Given this list of marker genes Aurkb, Ppp2cb, Ska1, Ndel1, Ppp2r1a, Brk1, Dynll1, Diaph2, Rhod, Seh1l, Nckipsd, Mapre1, Pafah1b1, Cenpk, Clip1, Ndc80, Evl, Ywhae, Cenps, Incenp, Noxo1, Prkcz, Ppp2r5a (NCBI Gene Id 226849), Cenpq, Nox1, Diaph1 (diaphanous related formin 1), Sgo1, Kif18a, Kif2b, Dync1i1, Klc3, Tubb2b, Dync1li1, Nup85, Clasp2, Ctnnb1, Tuba3b, Fmnl3, Pik3c3, Myl6, Tubb2a (NCBI Gene Id 263448), Gopc, Dsn1 (NCBI Gene Id 99407), Cenpe, Fmnl1, Ahctf1, Ppp1r12b, Kif2a, Kif14, Kntc1 (kinetochore associated 1), Flna, Myh14, Rps27, Ncf2, Ercc6l, Pak2, Actb, Rcc2, Spc25, Kif2c, Cyfip1, Rac2, Cybb, Ptk2, Zw10, Myh9, Rhob, Ppp2r5d, Plk1, Nup107, Arpc1a, Pfn2, Rhoa, Daam1, Ar, Mad2l1, Nup133, Cenph, Cenpn, Nuf2, Abi1, Rhoc, Wasf2 (NCBI Gene Id 52063), Mis12, Fmnl2 (NCBI Gene Id 71409), Nckap1, Ywhag, Calm2, Nudc, Tubb1 (tubulin, beta 1 class VI), Dvl1, Ywhah, Myl12b, Ppp1cc, Cftr, Ywhaz, Ncf1, Wasf1, Ywhab (NCBI Gene Id 80438), Wasf3, Nf2, Noxa1, Dvl2, Ppp2r5b, Dlg4, S100a9, Nup37, Pkn2, Mapk1, Pin1, Tubb4b, Rps27rt (ribosomal protein S27, retrogene), Prkcb, Tuba8, Ppp1cb, Srgap2, Tubb3, Arpc4, Rangap1, Tuba1b, Nup43, Rhpn2, Lin7b, Myl9, Tuba3a, Clasp1, Rhpn1, Cenpi, Tax1bp3, Mapk14, Calm3, Nckap1l, Cenpo, Cdc25c, Grb2 (growth factor receptor bound protein 2), Sec13, Cyba, Kif5a, Tuba4a, Pfn1, Zwint, Dync1i2, Dync1li2, Nox3, Btk, Klc4, Wipf1 (NCBI Gene Id 98855), Bub1b, Ppp1r14a, Cdc42, Wipf3, Bub1, Cenpp, Sfn, Rhog, Itgb3bp, Mapk3, Srf, Tubb6, B9d2, Pmf1, Myh11, Dvl3, Iqgap1, Myh10, Iqgap3, Pak3, Arpc5, Klc1, Zwilch, Arpc2, Ranbp2, Dync1h1, Nup160, Ncf4, Nck1, Rac1, Tuba1a, S100a8, Baiap2, Ppp2ca, Actr3, Ctnna1, Prc1, Tubal3, Cenpc1, Kif5b, Nup98, Ska2, Nde1, Iqgap2, Rhoq, Tuba1c, Scai (NCBI Gene Id 99056), Rock1, Pkn1, Ktn1, Sgo2a, Abl1, Cdc20, Actg1, Src, Tubb4a, Ppp2r5e, Prkcd, Nsl1, Men1, Ywhaq, Actr2, Mrtfa, Cdca8, Spc24, Mad1l1, Klc2, Ckap5, Cyfip2, Mapk11, Arpc3, Cenpf, Limk1, Ncoa2, Bub3, Cenpm, Rock2, Taok1, Ppp2r1b, Xpo1, Pkn3, Cenpa, Diaph3, Pik3r4, Rtkn, Arpc1b, Mylk, Ppp1r12a, Calm1, Ppp2r5c, Cenpu, Pak1, Pdpk1, Cenpt, Dynll2, Abi2, Cenpl, Spdl1, here is a description of the gene set: Mouse Gene Set: REACTOME_RHO_GTPASE_EFFECTORS studied in species Mus musculus RHO GTPase Effectors